Given this list of marker genes BTG2, GPR3, ITGB5, PSMD3, DDX52, EDC4, PRKDC, SEMA6A, MNT, TXNDC9, NRTN, TFEC, TMT1A, FILIP1L, TSC22D3, PSMB9, SLC35D2, LRRC8B, IQSEC2, ZNF44, GPKOW, PRKCSH, TARBP1, RPIA, SIGLEC6, GREM1, CRKL, KHDRBS3, ENPP2, SEPTIN11, SPRR2D, CDK9, TSFM, ASIC1, DDX17, MAN2B1, LRP10, RNF103, TM9SF1, DLEC1, THOP1 (thimet oligopeptidase 1), QKI, IDH2, MYD88, ARF5, SNRPE (NCBI Gene Id 6635), XPO6, RELA, VAMP5, RNASE2, TMSB4Y, DDX5, CYB5R3, H2AZ2 (H2A.Z variant histone 2), AMHR2, IFITM2, LPAR4, CDC16, SLC25A36 (NCBI Gene Id 55186), MT1E, GPR15 (G protein-coupled receptor 15), HAP1, NOVA2, DCHS1 (dachsous cadherin-related 1), TERF2IP, STC2, DEFB1, CSK, MBTPS1, RNF113A, EIF3M, NUDCD3 (NCBI Gene Id 23386), ARR3, RPA1, RAB5C (RAB5C, member RAS oncogene family), TAFAZZIN, STARD3, LMO2, ZNF623, LTBP4, TARS1, PMS2P11 (PMS1 homolog 2, mismatch repair system component pseudogene 11), GRIK5, ATF3, SERPINF1, AP3S2, ANKS1A, TLE4, PI4K2A, SPHK2, KCNJ1, ZNF20, SLC18A2, TANK, BRD2, DUSP11, FLAD1, RFX2, CD38, GRK5, PPIE, PDIA4, ST14, TCF12, MAP3K8, PNN, IRF1, ANGPTL7, ACAA1, TRIP6 (thyroid hormone receptor interactor 6), PCBP3, BTBD3, TSC22D2, LGALS3BP (galectin 3 binding protein), LAGE3, ACYP1, PTGER2, AQP8, AASS, PTGDS, HCCS, CNOT3, VGLL4, BCAS2, HOMER3, PRKACA, ISG20L2, CYC1, TMPRSS2, CAMK2B, CNPY3, SLC13A2, IFFO1, EXOSC8 (NCBI Gene Id 11340), P2RX4, CMKLR1, HEXB, TRIOBP, POLD3, EML2, AP2A2, GRM4, TGDS, PPM1G, DDX46, MUC6, STAG2, CR2, CYB5A, ATP5F1B, REM1, LGMN, NACC2, PPM1A, PBX2 (PBX homeobox 2), RFK, ITPK1, SCN9A, NFYB, ATXN1, SULF1, SREBF1, GNAO1, TIPARP, C15orf39, ADGRL2, ZZEF1, FGFR2, F7, CALML3, TMEM268, PDCD10, E2F1, EPB41, LIAS, TNR, PKIG, PLIN1, NCOR2, RIN2, GOLGA8A, PLP2, PCDH7, ATP6V1C1, PYGM, TMED3, ARHGEF1, CUL9, HSPA5, PDCD4, LSM3, HTR1B, IFI44L, MSC, RRH, NELFB, FLII, HRC, CCSER2, TNFRSF25, here is a description of the gene set: Genes down-regulated in comparison of macrophages exposed to 50 worms/well B. malayi versus those exposed to 5 worms/well B. malayi. from publication Chaussabel D, Semnani RT, McDowell MA, Sacks D, Sher A, Nutman TB (PMID 12663451) studied in species Homo sapiens Monocyte-derived dendritic cells (DC) and macrophages (MΦ) generated in vitro from the same individual blood donors were exposed to five different pathogens, and gene expression profiles were assessed by microarray analysis. Responses to Mycobacterium tuberculosis and to phylogenetically distinct protozoan (Leishmania major, L. donovani, Toxoplasma gondii) and helminth (Brugia malayi) parasites were examined, each of which produces chronic infections in humans yet vary considerably in the nature of the immune responses they trigger. Human Gene Set: GSE360_HIGH_VS_LOW_DOSE_B_MALAYI_MAC_DN